Given this list of marker genes Katna1, Katnal2, Lzts2, Ttll6, Ttll11, Fignl2, Katnb1, Katnal1, Spast, here is a description of the gene set: studied in species Mus musculus Mouse Gene Set: GOBP_MICROTUBULE_SEVERING The process in which a microtubule is broken down into smaller segments. Severing enzymes remove dimers from the middle of the filament to create new ends, unlike depolymerizing kinesins that use ATP to uncap microtubules at their ends.